Given this list of marker genes RORB, PLA2G6, KCNC2, ATP1A3, RORA (RAR related orphan receptor A), GRIN1, SLC6A1, ASAH1, DHFR, here is a description of the gene set: Marked, involuntary jerking of the eyelids. Human Gene Set: HP_EYELID_MYOCLONUS Eyelid myoclonus studied in species Homo sapiens